The following is a description of a gene set: Human Gene Set: PID_AURORA_B_PATHWAY Aurora B signaling species: Homo sapiens from publication Schaefer CF, Anthony K, Krupa S, Buchoff J, Day M, Hannay T, Buetow KH (PMID 18832364), and this is the list of marker genes: TACC1, PPP2R5D, MYLK, CDCA8, RACGAP1, AURKB, STMN1, NCAPD2, DES, NDC80, NSUN2, KIF20A (NCBI Gene Id 94421), AURKC, BUB1, NCL, SMC4 (structural maintenance of chromosomes 4), SGO1, NCAPH, NPM1, INCENP, CENPA, KIF2C, RHOA, KIF23, RASA1, KLHL9, AURKA, PSMA3, CBX5, CUL3, SMC2, VIM, PPP1CC, KLHL13, NCAPG, EVI5, BIRC5, SEPTIN1, PEBP1